The following is a description of a gene set: species: Homo sapiens from publication Chen Y, Wang X (PMID 31504780) Human Gene Set: MIR512_3P Genes predicted to be targets of miRBase v22 microRNA hsa-miR-512-3p in miRDB v6.0 with MirTarget v4 prediction scores > 80 (high confidence targets)., and this is the list of marker genes: NOD1, LRRC8B, SLC6A11, CXXC5, SLC16A6 (solute carrier family 16 member 6), GIPC2, CAMTA1, PLPP4, KAT6A, ZFYVE16, ZNF213, HPRT1, ZFHX3, FEM1C, NFIB, RND3, GAS2, ZDHHC3, BICC1, DYRK2, C1orf21, DDI1, TM2D3, TP53INP1, CPM, PCYT1B, ATXN1, PPP4R3B, ATXN7, EPC1, ESRP2, FAT4, ABHD18, RNF38, ZNF827, PFKP, PXYLP1, SNRNP200, NR2E1, PHACTR4, SPOP, KLB (klotho beta), CDK19, HLF, ADAM18, ERBB3, PRKAR2A (NCBI Gene Id 5576), QSER1, FOXK2, MARCHF8, MLLT6, MYT1L, CYP2U1, CUBN, CADM2 (NCBI Gene Id 253559), AHRR, EFCAB5, ADCY1, AGTR2, TTC23, IL6ST, PIK3R5, PPP3CA, JMJD1C (NCBI Gene Id 9323), ARHGEF10, TNKS2, TRAK1, TTPAL, PDIK1L, CCDC6, FGL2, ARL5B, RABEP1, PTPN4, CEP43, CYSTM1, AKTIP, THRB, SLAIN2, PPARA, DOCK3, ZNF711, MAPK10, ARL17A, GON4L, SFMBT1, CUX1, SMAD9, ZNF24, CAPRIN2 (NCBI Gene Id 84116), SELENOT, ZC3H12C, USP46, PFN2, TP63, ABL2, PTBP2, USP3, TRHDE, GXYLT1, MAST4, PTCHD1, ZFR, TANC1, ZNF12, ADAMTSL3